Given this list of marker genes Mecp2, Fosb, Ppp5c, Ppp1r1b, Drd2, Adcy8, Drd3, Ppp2r2a, Cartpt, Adra1b, Gria1, Arc, Oprm1, Npy1r, Adra2a, Prkcg, Slc1a1, Ppp1r9b (protein phosphatase 1, regulatory subunit 9B), Prkce, Grin1, Abcb1a, here is a description of the gene set: species: Mus musculus Any process that results in a change in state or activity of a cell or an organism (in terms of movement, secretion, enzyme production, gene expression, etc.) as a result of an isoquinoline alkaloid stimulus. An isoquinoline alkaloid is any member of a group of compounds with the heterocyclic ring structure of benzo(c)pyridine which is a structure characteristic of the group of opium alkaloids. Mouse Gene Set: GOBP_RESPONSE_TO_ISOQUINOLINE_ALKALOID